Given this list of marker genes HAVCR2, ADA2, IL15, SMCO4, NOD2, BLVRA, MICB, SUSD1, MS4A3, ANKRD22, NAGK, SNTB1, LHFPL2, EMILIN2, SLC37A2, CYBB, NUB1, TNS3, PLAGL2, ADAP2, TLR7, STAT2, APOL3, SIL1, EPB41L3, CD86 (NCBI Gene Id 942), WARS1, TAP1, RGS12, IFI30, DHX58 (NCBI Gene Id 79132), HK2, CD163, LGALS9, TTYH3, CNDP2, NPC2, NAGA (alpha-N-acetylgalactosaminidase), TMEM268, RTCB, MYOF, FLVCR2 (FLVCR choline and putative heme transporter 2), NLRP3, KCNMB1, SCIMP, FCN1, SORT1 (NCBI Gene Id 6272), KYNU, SCARB2 (scavenger receptor class B member 2), CD74, here is a description of the gene set: Human Gene Set: GAUCHER_PBMC_YF_VAX_STAMARIL_UNKNOWN_AGE_60DY_UP from publication Gaucher D, Therrien R, Kettaf N, Angermann BR, Boucher G, Filali-Mouhim A, Moser JM, Mehta RS, Drake DR 3rd, Castro E, Akondy R, Rinfret A, Yassine-Diab B, Said EA, Chouikh Y, Cameron MJ, Clum R, Kelvin D, Somogyi R, Greller LD, Balderas RS, Wilkinson P, Pantaleo G, Tartaglia J, Haddad EK, Sékaly RP (PMID 19047440) Genes up-regulated in peripheral blood mononuclear cell 60d vs 0d in unknown after exposure to YF-Vax/Stamaril, time point 60D studied in species Homo sapiens Correlates of immune-mediated protection to most viral and cancer vaccines are still unknown. This impedes the development of novel vaccines to incurable diseases such as HIV and cancer. In this study, we have used functional genomics and polychromatic flow cytometry to define the signature of the immune response to the yellow fever (YF) vaccine 17D (YF17D) in a cohort of 40 volunteers followed for up to 1 yr after vaccination. We show that immunization with YF17D leads to an integrated immune response that includes several effector arms of innate immunity, including complement, the inflammasome, and interferons, as well as adaptive immunity as shown by an early T cell response followed by a brisk and variable B cell response. Development of these responses is preceded, as demonstrated in three independent vaccination trials and in a novel in vitro system of primary immune responses (modular immune in vitro construct system), by the coordinated up-regulation of transcripts for specific transcription factors, including STAT1, IRF7, and ETS2, which are upstream of the different effector arms of the immune response. These results clearly show that the immune response to a strong vaccine is preceded by coordinated induction of master transcription factors that lead to the development of a broad, polyfunctional, and persistent immune response that integrates all effector cells of the immune system.